Given this list of marker genes ST3GAL1, HID1 (HID1 domain containing), YIPF1, GCC1, SGMS1, YIPF2, TMEM59, B4GALT1, YIPF6, here is a description of the gene set: The Golgi cisterna farthest from the endoplasmic reticulum; the final processing compartment through which proteins pass before exiting the Golgi apparatus; the compartment in which N-linked protein glycosylation is completed. species: Homo sapiens Human Gene Set: GOCC_GOLGI_TRANS_CISTERNA